Given this list of marker genes SLC7A10, SLC6A5, GLRA1, GLRB, SLC6A9, here is a description of the gene set: studied in species Homo sapiens Human Gene Set: GOBP_SYNAPTIC_TRANSMISSION_GLYCINERGIC The vesicular release of glycine from a presynapse, across a chemical synapse, the subsequent activation of glycine receptors at the postsynapse of a target cell (neuron, muscle, or secretory cell) and the effects of this activation on the postsynaptic membrane potential and ionic composition of the postsynaptic cytosol. This process encompasses both spontaneous and evoked release of neurotransmitter and all parts of synaptic vesicle exocytosis. Evoked transmission starts with the arrival of an action potential at the presynapse.